The following is a description of a gene set: from publication Cui A, Huang T, Li S, Ma A, Pérez JL, Sander C, Keskin DB, Wu CJ, Fraenkel E, Hacohen N (PMID 38057668) Genes positively differentially expressed in cell type: pDC (plasmacytoid dendritic cell) upon treatment with cytokine: IFN-ε in mouse lymph nodes in vivo. Mouse Gene Set: CUI_PDC_IFNE_RESPONSE_UP Cytokines mediate cell-cell communication in the immune system and represent important therapeutic targets. A myriad of studies have highlighted their central role in immune function, yet we lack a global view of the cellular responses of each immune cell type to each cytokine. To address this gap, the authors created the Immune Dictionary, a compendium of single-cell transcriptomic profiles of more than 17 immune cell types in response to each of 86 cytokines (>1,400 cytokine-cell type combinations) in mouse lymph nodes in vivo. A cytokine-centric view of the dictionary revealed that most cytokines induce highly cell-type-specific responses. For example, the inflammatory cytokine interleukin-1β induces distinct gene programmes in almost every cell type. A cell-type-centric view of the dictionary identified more than 66 cytokine-driven cellular polarization states across immune cell types, including previously uncharacterized states such as an interleukin-18-induced polyfunctional natural killer cell state. studied in species Mus musculus, and this is the list of marker genes: Oasl2 (2'-5' oligoadenylate synthetase-like 2, NCBI Gene Id 23962), Sct, Ifi44, Rnf213, Ly6c2, Ly6a, H2-T23, Ccnd1, Ifitm3, Psme2, Apod, Ifi27l2a, Sdc3, Zbp1, Tapbp, Ptms, Phf11b, Smim5, Hmgcs1, Isg15, Tmsb10, Arf4, S100a6, Shisa5, Pfn1, Trim30d, Fcer1g (Fc receptor, IgE, high affinity I, gamma polypeptide), Atp6v1d (ATPase, H+ transporting, lysosomal V1 subunit D), Ube2l6, Cnn2, Kdr, Dhx58, Isg20, Psme1, Lrp8, Irf7, Plac8, Slc25a46, Tubb4b, Selenow, Lgals3bp, Ifi203, Hck, Ifi35, Ass1, Sp100, Tspo, Ctsl